Given this list of marker genes SLC23A1, SLC29A1, SLC25A4, SLC28A3, SLC28A2, SLC29A2, SLC28A1 (solute carrier family 28 member 1), SLC43A3, AQP9, SLC25A5, SLC29A3, here is a description of the gene set: species: Homo sapiens Human Gene Set: GOMF_NUCLEOBASE_TRANSMEMBRANE_TRANSPORTER_ACTIVITY Enables the transfer of a nucleobase, any nitrogenous base that is a constituent of a nucleoside, nucleotide, or nucleic acidfrom one side of a membrane to the other.